Given this list of marker genes Adora3, Adora2a, P2ry12, Oxgr1, Adora2b (adenosine A2b receptor), Adora1, here is a description of the gene set: Combining with adenosine and transmitting the signal across the membrane by activating an associated G-protein; promotes the exchange of GDP for GTP on the alpha subunit of a heterotrimeric G-protein complex. studied in species Mus musculus Mouse Gene Set: GOMF_G_PROTEIN_COUPLED_ADENOSINE_RECEPTOR_ACTIVITY